Given this list of marker genes Igf1, Atxn7, Atxn1, Igfbp5, Trim72 (NCBI Gene Id 434246), Igfbp4, Ar, Cdh3, Igfbp1, Bmp5, Cilp (NCBI Gene Id 214425), Bmp2, Phip, Nkx3-1, Ift88 (NCBI Gene Id 21821), Inppl1, Igfbp3, Myorg, Ghsr, Pou1f1, Igfbp6, Zfand2b, Ghrhr, Wnt1, Igfbp2, here is a description of the gene set: studied in species Mus musculus Mouse Gene Set: GOBP_REGULATION_OF_INSULIN_LIKE_GROWTH_FACTOR_RECEPTOR_SIGNALING_PATHWAY Any process that modulates the frequency, rate or extent of insulin-like growth factor receptor signaling.